Given this list of marker genes Eng, Smad3, Tgfb2, Smad6, Smurf2, Amh, Snx6, Cd44, Lefty1, Smad7, Tgfbrap1, Tgfbr3, Tgfbr2, Map3k7, Lefty2, Usp15, Smurf1, Fkbp1a, Fermt2, Lrg1, Tgfbr1, Smad2, Tgfbr3l, Tgfb3, Rasl11b, Tgfb1, Gdnf, Snx25, here is a description of the gene set: Binding to a transforming growth factor beta receptor. Mouse Gene Set: GOMF_TRANSFORMING_GROWTH_FACTOR_BETA_RECEPTOR_BINDING studied in species Mus musculus